The following is a description of a gene set: Human Gene Set: GOBP_LYMPHOCYTE_MEDIATED_IMMUNITY species: Homo sapiens Any process involved in the carrying out of an immune response by a lymphocyte., and this is the list of marker genes: UFL1, SECTM1, CCR2, RNF8, PTPN6, CYRIB, CD274, IL21, KLRC3, KLRC2, STX7 (syntaxin 7), IGLC6, GFUS, IGHV1-18, PMS2, PCYT1A (phosphate cytidylyltransferase 1A, choline), PAXIP1, SERPINB4, MAP3K7, KIR2DL4, LILRB4, IGLL5, HPRT1, IGHA1, IL9, ARL8B, IL6, TAP2, DENND1B (NCBI Gene Id 54530), FCRLB, SUSD4, IGHG3, CD70, KLRC4, PRKAA1, IGHA2, HLA-DRA, ARRB2, IGHV3-13, PIK3R6, IGHD, IL12A, IGHV3-23, HSPD1, IL18R1, IGHV1-3, C4A, C17orf99, IGHV3-15, CD19, AZGP1, IGLC3, EBAG9, ULBP3 (NCBI Gene Id 79465), CSF2RB, CEACAM1, GZMM, TUBB4B, TRAF6 (NCBI Gene Id 7189), GATA3, CD8A (CD8 subunit alpha), ATAD5, SLAMF7, HCST, SANBR, ARID5A, IGHG4, BCL6, TNFRSF1B, RNF168, KMT5C, IL12RB1, CD1E, CD96, CRK, IL13RA2, CD1A, C4BPB, C8B, IGHV2-5, HLA-DRB1, IGHV3-30 (NCBI Gene Id 652651), TP53BP1, IGHE, TUBB, CD1C, RAET1E, CADM1, GNL1, KIR3DL1, PIK3R1, BTN3A3 (NCBI Gene Id 135583), BTN3A2, C8G, IGHV1-69D, C4B, NSD2, NCR3, IGHV3-16, HLA-C, LAMP1, EXOSC3, CORO1A, UNC13D, CR1L, CD160, FCGR3A, EMP2, CD27, IGHV3-20 (NCBI Gene Id 28445), MALT1, KLRD1, IGHV1-24, HMCES, KIF5B, ARG1, C1RL, FCGR1BP, IGHV5-10-1, IGHV2-70D, KDM5D, IGLC1, TNF, TREM2, RASGRP4 (RAS guanyl releasing protein 4), HMGB1, XCL1, IGHV3-11, USP5, STAT5A, FCER1A, IGHV3-33, IGHV2-26, EXO1, KLHL22, FADD, RFTN1, IL18, APLF, MAPK3, DUSP22 (dual specificity phosphatase 22), IGHV3-72, FZD5, AICDA, TRPM4, IGHV1-58, ZBTB1, SHLD1, IGHV3-43, FBXO38, IL10, CLU, KLRC1 (NCBI Gene Id 3821), CD1D (NCBI Gene Id 912), ULBP1, C7, FCGR2C, NCKAP1L, STAT6, AP1G1, FCGR3B, CTSC, IGHV6-1 (immunoglobulin heavy variable 6-1), PLEKHM2, IGHV3-64D, IGHG2, IL12B, HLA-E, IRF7, LTA, IGHV2-70, IGKC, CD40 (NCBI Gene Id 958), YWHAG, KMT5B, IGHV3-74, STAT5B, CD40LG, IGHV4-61, P2RX7, PVR, CD55, NBN, RNF19B, IGHV3-73, HLA-B (major histocompatibility complex, class I, B), IL9R, NKG7, KLRB1, IGHV4-31, IL4R, FCMR, FCER2, CLEC4G, HLA-DRB3, IGHV3-49, MICA, UNC93B1, CD74, FCER1G, CLC, CD81, RIF1, GRB2, LGALS9, IGLC7, SH2D1B, CD1B, RAET1L (retinoic acid early transcript 1L), RIPK3, KLRF2, CALHM6, CTSH, NECTIN2, FUT7, SLAMF6, CEBPG, IGHV3-48, SCART1, HLA-F, IGHV3-21, IGLC2, IL23A, MASP2, FCGR2B, WAS, C9, PDCD1, ICAM1, CR1, IGHV4-39, TLR8, SHLD3, NLRP3, TREX1, IGHV7-81 (NCBI Gene Id 28378), C1QC, C4BPA, NFKBIZ, TCIRG1, PRF1, IL4, TRAF3IP2, HLA-H, MLH1, KLRC4-KLRK1, PRKCZ, C3, VAMP7, TRAF2, CD2, SH2D1A, C8A, IGHV3-53, CLEC12B, TNFSF4, FOXP3, IGHV4-59, PRDX1, IL23R, IFNA2, IGHV3-38, IGHV1-45 (immunoglobulin heavy variable 1-45), IL2RB, LAG3, AIRE, HPX, CD46, MSH6, TNFSF13, HLA-A, SLA2, SUPT6H, CRTAM, HLA-G, NDFIP1 (NCBI Gene Id 80762), JAG1, ZP3, BCL10, C1QA, IGHV1-69, TBX21, PIK3CB, IL7R, C1QBP, CD80, IGHG1, MAD2L2, ERCC1, IL4I1, LEP (NCBI Gene Id 3952), RAB27A, HAVCR2, FCGR2A, SPN, IGHV3-35, C5, TGFB1, TYROBP, IGHV7-4-1, RAET1G, PRKCD, SLC15A4, CARD9 (caspase recruitment domain family member 9), ULBP2, RASGRP1, MYD88, NCR1, CR2, SMAD7, IL27RA, CLEC2A, LILRB1, IGHV3-7, MBL2, TIGIT, BCL3, SERPINB9, CD28, PARP3, B2M, FOXJ1, CLNK, IGHV8-51-1, IL18RAP, SLAMF1 (NCBI Gene Id 6504), CCR6, TFRC, UNG (uracil DNA glycosylase), SHLD2, EXOSC6, NECTIN4, KLRK1, MYO1G (myosin IG), IGHV3-64, IGHV1-69-2, IL1R1, RSAD2, IGHV4-4, VAMP2, SASH3, C2, IFNB1, BATF, LIG4, IGHV3-66, C1S, IL20RB, IGHV4-34, HFE, GZMB, IGHV5-51, BTK, IL2, CFI, PTPRC, MR1, IGLL1, VAV1 (NCBI Gene Id 7409), PPP3CB, IL1B, IGHV4-28, MSH2, CD7, CLCF1, LYST, CD226, INPP5D, AGER, C1QB, FCGR1A, SWAP70, C1R, C6, SLC22A13, AHR, SERPING1